The following is a description of a gene set: studied in species Homo sapiens from publication Fan X, Dong J, Zhong S, Wei Y, Wu Q, Yan L, Yong J, Sun L, Wang X, Zhao Y, Wang W, Yan J, Wang X, Qiao J, Tang F (PMID 29867213) Human Gene Set: FAN_EMBRYONIC_CTX_BRAIN_B_CELL, and this is the list of marker genes: CD79A, HLA-DMB, CD22, CYB561A3, BMS1P20, HLA-DMA, PLEKHA2, ISG20, CXCR4, CD74, PTPN6, ARHGAP15 (NCBI Gene Id 55843), CRIP1, PDLIM1, SMIM14, HLA-DQB1, SLC38A1, SP110, ARID5B, FCRL1, CD69, AFF3, SWAP70 (NCBI Gene Id 23075), PIM2, CD48, LSP1, ELF1, FCRLA, ATP2A3 (NCBI Gene Id 489), NIBAN3, CD72, QRSL1, CD47, CD19, SEPTIN6 (septin 6), PLAC8, SP140, CD37, HLA-DRA (major histocompatibility complex, class II, DR alpha), PTPRCAP, HLA-DRB1, ALOX5, LY9, BIRC3, PPP1R14A, IL2RG, EBF1, CD79B, ADD3, IKZF3, ACAP1, P2RX5, CYTIP, VPREB3, NCF1C, NCF1, PCNP (PEST proteolytic signal containing nuclear protein), SEPTIN1, TCL1A, TTN, HLA-DPA1 (major histocompatibility complex, class II, DP alpha 1), TAGLN2, LINC00926, PSME1, UTRN, CD55, HLA-A, RPL13A, FCRL2, TXNIP, FCMR, RAC2, PSMB9, EEF1D, IGLL5, PSME2, SPIB, PAX5, RHOH, SYTL1, MS4A1, HLA-DPB1, KIAA0040, GAS5, LINC01781, HLA-C, LIMD2, LTB, RIPOR2, CORO1A, HLA-B, CD52, BTG1, RALGPS2, PDE4B, CLEC2D, HLA-DQA2, BANK1, BCL7A, GPR18, MZB1